The following is a description of a gene set: Human Gene Set: GOCC_RIBOSOMAL_SUBUNIT species: Homo sapiens Either of the two subunits of a ribosome: the ribosomal large subunit or the ribosomal small subunit., and this is the list of marker genes: MRPL57, MRPS2, RPS8, MRPL43, TIFAB, RPL29 (ribosomal protein L29), RPL10A, MRPS28, MRPL39, MRPL22, MRPL16, GADD45GIP1, MRPL24, MRPS9, RPLP1, RPL28, RPL26L1, RPL37AP8, RPL10L, MRPL28, RPS27A, RPS15A, RPS2, MRPS14, MRPS15 (mitochondrial ribosomal protein S15), MRPS18C, RPS16, MRPS34, MRPL53, RPL7A, MRPL19, MRPS16, RPL21, MRPS27, MRPS7, MRPL18, RPL9, RPS20, RPS6, MRPS26, RPL36, RPL4, RPL22, RPL38, MRPS17, MRPL38, RPS28, MRPL21, RPS14, MRPS10, NSUN3, RPL12, RPL35A, RPL18A, RPS11, RPS9, MRPS6, RPL24, MRPL17, RPS17, RPL3, MRPL36 (mitochondrial ribosomal protein L36), RPL27, MRPL49, RPL39L, MRPL45, RACK1, MRPS30, MRPS23, MRPL4, MRPL51, RPS19, MRPL30, MRPL23, RPL41, UBA52, RPL10, RPL3L, RPL37A, RPL18, MRPL14, RPS24, MRPL11, MRPL2, MRPS33, RPL7L1, RPS12, RPS27L, RBM3 (RNA binding motif protein 3), RPL5, RPL14, ZCCHC17, MRPS18B, DAP3, MRPS21, RPL6, DHX29, RPL19, RPS5, RPL34, RPS3A, MRPL10, MRPL35, MRPS12, RPS21, MRPL12, RPL17, MRPS18A, RPS25, MRPS11, RPL26, MRPS25, RPS10P5 (NCBI Gene Id 93144), RPS15, RPL13A, MRPS22, RPL15, RPLP2, MRPL47, MRPS31, RPL30, MRPL15, RPL27A, MRPL32, MRPL41, MRPL54, RPL32, RPL39P5, CHCHD1, RPL36AL, MRPL48, RPL11, RPL36A, MRPL34, RPL23, RPL13, MRPL20, RPL35, RPS27, NSUN4, RPS7, MRPS24, RPL37, MRPL27, MRPS35, RPLP0, RPS4Y2, RPSA2, RPS13, RPL8, MRPS5, MRPL52, EIF2A, MRPL46, MRPL44, MRPL13, RPL31, NPM1, DDX3X, MRPL50, RPS26, LARP4, RPS4Y1 (NCBI Gene Id 6192), MRPL58, RPS18, FAU, RPS29, RPS3, RPL39, RPLP0P6, RPS10, MRPL33, AURKAIP1, MRPL37, MRPL3, PTCD3, RPL7, MRPL40, MRPL1, MRPL55, RPS4X, RPS23, MTERF4 (mitochondrial transcription termination factor 4), RPL23A, MRPL42, RPSA, MRPL9